The following is a description of a gene set: species: Homo sapiens Any process that modulates the frequency, rate or extent of cell maturation. Human Gene Set: GOBP_REGULATION_OF_CELL_MATURATION, and this is the list of marker genes: TMPRSS12, BCL11A, TCP11X2, TRIM58, SIRT2, NGF, TBX6 (NCBI Gene Id 6911), RAC1, BCL2, TCP11, NPPC, LRRK2, BNC1, ADAM7, PAEP, TCP11X1, KIF14, WEE2, RAC3, CLEC7A, SHB, NPR2, AURKA, MAP3K13, EDNRB